The following is a description of a gene set: studied in species Homo sapiens from publication Hutcheson J, Scatizzi JC, Siddiqui AM, Haines GK 3rd, Wu T, Li QZ, Davis LS, Mohan C, Perlman H (PMID 18275831) Gene expression profile studies have identified an interferon signature in whole blood or mononuclear cell samples from patients with systemic lupus erythematosus. This study was designed to determine whether specific lymphocyte and myeloid subsets freshly isolated from the blood of systemic lupus erythematosus patients demonstrated unique gene expression profiles compared to subsets isolated from healthy controls. Human Gene Set: GSE10325_BCELL_VS_LUPUS_BCELL_UP Genes up-regulated in comparison of healthy B cells versus systemic lupus erythematosus B cells., and this is the list of marker genes: NTRK1, DNAJC17, RPL26, LTA4H, IGHG1, NR5A1, BDH1, TNF, ASPSCR1, GPR35, CTSF, ZNF768, RPL3, KANK3, CYP2R1, FNDC11, TCTN1, CD1C, APBA2, ABCG5, MIA, CTRB2, VEGFB, TPPP3, CLPS, AVIL, TMEM53, ZFP2, WDR25, SLC26A10P, SARM1, PITX1, FMO2, ACAP1, CST6, LHFPL2, SYBU, FAM234B, GCM2, MUC3A, AMHR2, DIRAS3, SLC41A3, ZNF419, ZNF671, SLC25A37, KCNN4, CRX, NCS1, EEF1A1, POF1B, BICDL1, POU1F1, CDIP1, LIMS2, TMEM19, TBC1D13, ZNF142 (NCBI Gene Id 7701), TFAP2B, GOLGA2P5, ZFTRAF1, ZNF253, PPM1F, MACROD1, MYO1E, OXT (oxytocin/neurophysin I prepropeptide), RGS14, TMEM161A, GSC2, KHDRBS3, KLK1, GRIA3, FBP1, PRSS50, TGM1, SERGEF, TMEM63A, ASPHD1, LTB, RPL6, TP53AIP1, SEMA3D, CNNM4, SPAG11A, HRH2, CHMP7, HSPB2, C22orf31, PRDM12, TULP1, PYY, MMP2, ZNF813, ASB13, NEBL, ZNF778, ZCCHC24, TOP3B, FBXO42, DPT (NCBI Gene Id 1805), RECQL5, DOC2A, ABO, MIR600HG, RNASEL, PDZRN3, H1-1, HPN, H2AC18, SENP5, BAIAP3, NOL9, VCX2, CAMK2N1, HMHB1, AKR7A3, CNTN2, SMPD2, RPSA, GDPD3, KCND3, LDLRAD4, FBP2, RAB40A (NCBI Gene Id 142684), UBIAD1, CELSR3, HLCS, SLC6A8, OBP2A, SH3BP4, NPFF, CLDN7, PLPPR3, GPD2, RPS5, TNNI2, RPH3AL, RPS10P5, LAMC3, CCDC106, UNC5B, KCNMB4, CYP4F11, MRAS, CCL19, MARCKSL1, KAT2A, GLS2, MAML3, NCAM1, LRRC36, SHH, PAIP2B, SEMA4C, SYNPO2L, DEPDC5, NSUN5P2, TMEM158, BTBD7, FNBP1L, ZMYM3, ABCB8, KNG1, RAB3A, FBLN2, CCDC40, ABCA3, LAMA5, SLC25A6, RPS3A, DSP, UCP1, GAL3ST1, EYA2, NKRF (NCBI Gene Id 55922), PGC, SNHG3, ADCK2, GABBR1, KCNH2, NFATC4, KIF26B, ATP9B, KYAT1, PYCR3, ASB1, PATJ, THAP3, SOX1, KRT6B, TBX1, RRP12, CLDN11, RACK1